The following is a description of a gene set: Comprehensive identification of all functional elements encoded in the human genome is a fundamental need in biomedical research. Here, we present a comparative analysis of the human, mouse, rat and dog genomes to create a systematic catalogue of common regulatory motifs in promoters and 3' untranslated regions (3' UTRs). The promoter analysis yields 174 candidate motifs, including most previously known transcription-factor binding sites and 105 new motifs. The 3'-UTR analysis yields 106 motifs likely to be involved in post-transcriptional regulation. Nearly one-half are associated with microRNAs (miRNAs), leading to the discovery of many new miRNA genes and their likely target genes. Our results suggest that previous estimates of the number of human miRNA genes were low, and that miRNAs regulate at least 20% of human genes. The overall results provide a systematic view of gene regulation in the human, which will be refined as additional mammalian genomes become available. species: Homo sapiens Human Gene Set: TAAWWATAG_RSRFC4_Q2 from publication Xie X, Lu J, Kulbokas EJ, Golub TR, Mootha V, Lindblad-Toh K, Lander ES, Kellis M (PMID 15735639) Genes having at least one occurrence of the highly conserved motif M54 TAAWWATAG in the regions spanning 4 kb centered on their transcription starting sites. This matches the MEF2A transcription factor binding site V$RSRFC4_Q2 (v7.4 TRANSFAC)., and this is the list of marker genes: MUSK, SALL1, CDKN1A, TPP2, VEZF1, JUN, ACVR2A, ARPC5L, PLPP7, KCNJ9 (NCBI Gene Id 7820), MID2, FGF13, RNF207 (ring finger protein 207), MIA2, GYG1, MYL1, TMEM71, CNMD, HRK, NEB, SLC9A5, ADAM23, ANP32CP, PER1, EIF5A, ACTC1, NFAT5, PTCHD4, SV2A, XIRP1, HOXA9, MYL3, RALY, CLDN14, IP6K2, USP13, C10orf71, LRRC20, CUX1, TCEA3, ANKRD44, KCNA7, NRXN3, TACSTD2, DOCK8-AS1, DZIP1L, BEST3, ARHGAP26, HIBADH, WT1-AS, DIP2B, TCF4, GRIA3, KCNA3, NEXN-AS1, FOXP1, TRPS1, TMEM38A, SLC12A8, PACS1, LGALSL, DGKI, ADAMTS14, YARS1, ATP2A3, CTNND2, SLC8A3, ZMYM2 (NCBI Gene Id 7750), LSMEM2 (NCBI Gene Id 132228), ARAP2, KLB, SHOX2, TRAK2, HDAC4, DLC1, SDHC, GPER1 (G protein-coupled estrogen receptor 1), GPR157, PRMT3, FBXO11, CPNE7, GDPD3, CPT1B, ST6GALNAC5, ALPK2, PLEKHH3, RNF145, GRB14, PDGFRA, RASGEF1B, ELAVL4, MAT2A, COL8A1, PURA (purine rich element binding protein A), ZFAND5, CAPN3, KY, PNMA1, LIF, EDEM1, KCNN1, DSPP, RAP2C, TP63, ZHX2, TRMT112, STAG2, NRP2, GARIN6, ESAM, KLHL41, PTCH1, TNNC1, KCNQ5, PRELID3A, HJV, SLN, KTN1, MYOCD, TNNC2, STRADB, TNNI1, PABPC4, KLF14, BEX2, PDLIM1, NLK, TCEAL7 (transcription elongation factor A like 7), CA7, PI15, NR4A1, RAP2B, ANP32D, SNAP25, USP2, SMPX, CKMT2, ARHGEF37, INPPL1, MYOG, PCDH9, SATB2, PRDX5, SOX5, SEMA6A, LPAR4, ALDOA, WBP4, GARRE1, NOG, PPP2R3A, COL1A1, ZRSR2, ZNF385B, FILIP1, PPARGC1A, ARMCX6, ATXN1, DNAJA4, ESR1, MORC4, SLC2A4, TYRO3, FXR1, CRTAP, GNB4, FITM1, JSRP1, CELA3A (NCBI Gene Id 10136), HOXA4, NREP, LZTS2